The following is a description of a gene set: Down-regulated genes in the subpopulation of invasive PyMT cells (breast cancer) compared to the general population of PyMT cells. Correlating tumor cell behavior in vivo with patterns of gene expression has led to new insights into the microenvironment of tumor cells in the primary tumor. Until now, these studies have been done with cell line-derived tumors. In the current study, we have analyzed, in polyoma middle T oncogene (PyMT)-derived mammary tumors, tumor cell behavior and gene expression patterns of the invasive subpopulation of tumor cells by multiphoton-based intravital imaging and microarray-based expression profiling, respectively. Our results indicate that the patterns of cell behavior that contribute to invasion and metastasis in the PyMT tumor are similar to those seen previously in rat MTLn3 cell line-derived mammary tumors. The invasive tumor cells collected from PyMT mouse mammary tumors, like their counterparts from rat xenograft mammary tumors, are a population that is relatively nondividing and nonapoptotic but chemotherapy resistant and chemotactic. Changes in the expression of genes that occur uniquely in the invasive subpopulation of tumor cells in the PyMT mammary tumors that fall on the Arp2/3 complex, capping protein and cofilin pathways show a pattern like that seen previously in invasive tumor cells from the MTLn3 cell line-derived tumors. These changes predict an enhanced activity of the cofilin pathway, and this was confirmed in isolated invasive PyMT tumor cells. We conclude that changes in gene expression and their related changes in cell behavior, which were identified in the invasive tumor cells of cell line-derived tumors, are conserved in the invasive tumor cells of PyMT-derived mouse mammary tumors, although these tumor types have different genetic origins. from publication Wang W, Wyckoff JB, Goswami S, Wang Y, Sidani M, Segall JE, Condeelis JS (PMID 17440055) Mouse Gene Set: WANG_TUMOR_INVASIVENESS_DN studied in species Mus musculus, and this is the list of marker genes: Igf2bp1, Abcd4, Vamp3, Atrn, Ss18l2, Marcks, Csf2rb, Plaa, Dlgap5 (DLG associated protein 5), Ccni, Sfpq, Cyth3, Ube2h, Mpv17, Rad21, Rad1, Bud31, Csad, Ctnnd1, Sec61a1, Skp1, Efna5, Emd, Rlim, Cd44, Coro1c, Ccl3, Mrtfb, Tgfbr3, Spin1, Uhrf1, Cnbp, Id2, Wdr26, Tcf7l2 (transcription factor 7 like 2, T cell specific, HMG box), Racgap1, Commd10, Prkcd, Myl4 (myosin, light polypeptide 4), Tbc1d10a, Atp6v1a, Rpl3, Myc, Lpar1, Arf1, Anxa4 (annexin A4), Limd1, Cd53, Tpm3, Pde6d, Rbpj, Rsrp1, Nras, Dlg1, Tgfb1i1, Tfb2m, Ptges3, Cp, Wnt4, Ajuba, Esyt1, Arvcf, Xdh, Tmem254, Ube2c, B2m, Dnase2a, Hsd17b10, Psmb1, Irak1, Tcea1, Myef2 (NCBI Gene Id 214124), Aplp2, Ppp1r7, Slc27a1, Pkp3, Jmjd6, Furin, Rangap1, Ly6e, Wdr1, Zc3h7a, Ttbk2, Nsd3, Exo1, Vapa, Stk39, Mia3, Ptx3, Il16, Mysm1, Cinp, Esd, Gnai2, Pml, Pcnp, Ivns1abp, Clk1, Insig2, Nufip2, Bnip3l, Rpl29, Ilf3, Tgoln1, Luc7l3, Kbtbd2, Msn, Cdc123, Nfib, Ppp2r2d, Iqgap1 (IQ motif containing GTPase activating protein 1), Ugdh (NCBI Gene Id 22235), Mrpl38, Spp1, Btg2, Ttc3, Lcp1, Rhag, Map3k1, Habp4, Hnrnph2, Calr4, Gm2a, Isg20l2, Col6a1, Tmed5, Smg7, Ppp1cb (protein phosphatase 1 catalytic subunit beta), Sirt3, Gnb1, AA388235, Eif3g, Eef1a1, Pex19, Trap1, Dync1li2, Abcg1, Birc6, Dhx15, Canx, Celf2, Fstl1, Npc1, Ergic2, Tcf25, Rbm5, 2700097O09Rik, Ankrd13a, Srrm1, Vbp1, Phtf2, Ccng1, Cacybp, Gtf3c4, Igfbp5, Rab11b, Cpox, Atp6v1b2, Atf4, Ap2a2, H1f0, Pbxip1, Mdfic, Myadm, Cd9, Ywhaq, Rpl7l1, Erbb3, Mrpl19, Mettl26, Actr2, Kars1, Msantd1, Gdi2, Ppp1r12a, Atp1b1, Slc50a1, B4galt1, Itm2b, Scyl1, Degs1 (NCBI Gene Id 98213), Mfng, Dph6, Spindoc (spindlin interactor and repressor of chromatin binding), Nomo1, Eno3, Ryk, Eci1, Ywhaz, Stx8, Nipsnap2, Aebp2, Ppp2r5c, Angel2, Wdfy1, Ube2l3, Rnf31, Dhrs3, Dars1, Btg1, Polr1b, Cebpa, Naa35, Klhl9, Tspyl1, Gsk3b, Litaf, Yme1l1, Nherf1, Il17f, Cdh1, Rnf4, Snhg7